The following is a description of a gene set: studied in species Homo sapiens Human Gene Set: GSE37301_MULTIPOTENT_PROGENITOR_VS_GRAN_MONO_PROGENITOR_DN Expression profiling of Rag2-deficient Ets1++ and Rag2-deficient Ets1-- mature NK cells and WT bone marrow progenitors, WT T cells, and WT Pro B cells Genes down-regulated in multipotent progenitors versus granulocyte-monocyte progenitors. from publication Ramirez K, Chandler KJ, Spaulding C, Zandi S, Sigvardsson M, Graves BJ, Kee BL (PMID 22608498), and this is the list of marker genes: SRP19, QSOX1, SERPING1, AP1AR (NCBI Gene Id 55435), GPC4, TOR1AIP2, FMOD, SAAL1, REEP1, PDIA5, SLC31A1, PSMA7, ART3, RELA, HDC, TRPM7, PI4K2A, DDR1, RNF19B, DAXX, FBXW4, MX2, CLIC4, GPD2, RIPK1, PROCR, OXCT1, ALOX12, LTBP2, TBK1 (TANK binding kinase 1), EXO1, KLF9, ANKRD1, FRYL, KLF6, LY75, IL6ST, TUBB6, CMTR1, TAPBP, LARS1, AGFG1, MARK1, IFIH1, NMI, CRYBG1, IFIT1B, CARS1, FAM3B, EIF2AK2, PNP (NCBI Gene Id 4860), LGALS3BP, GJA4, PSMB9, PSEN1, PACS1, CXCL10, GTF2H1, LYSMD2, TSR1, IFIT2, NCK1, ABCG1, G3BP2 (G3BP stress granule assembly factor 2), PML, PSMB10, MYD88, CASP4, SAMHD1, CCR9, RSAD2, PKDCC, CMPK2, MED28, IL13RA1, GPANK1, DBNL (drebrin like), DKK3, RAD52, SNX10, MMP13, PPA1, TAP1, B4GALNT2, PHC2, PYCR2, NUB1, INSIG1, TAB2, ARL2BP, WARS1, TRAFD1, ZNFX1, STAT1, CLDN8, PTPRC, ATP11A, ITPR1, BIRC3, NPDC1, CD3D, NOP2, PSMB8, CSK, NAMPT, EXTL3, INTS8, CARM1, USP18, ITGB3, PAGR1, IL7R, LMO7, BMPR1A, HIP1R (huntingtin interacting protein 1 related), TRDMT1, HSPA1A, XDH, S100A4, IRF8, MAP4K3, JUN, TMEM50B (transmembrane protein 50B), BATF3, IFRD1, LMO2, HLA-G, PPRC1, NFKB2, KITLG, TFDP1, UBA7, NR1H2, TSSK1B, CDH8, POLD3, GRAMD2B, PXK, HLA-DMA, C8orf33 (NCBI Gene Id 65265), SOCS2, APOBEC1, GBP7 (guanylate binding protein 7), OSMR, BDKRB2, RGCC, ADAM23, MTNR1A, LCN2, ISG15, DSC1, IRF1, HPCA, ISG20, GTF2F2, CRIPTO, CCL13, MARK2, GBP4, GLCE, UBL3, PLPPR2, TRIO, GTPBP2, IRF7, RAD1, ADAM9, ATAD1, PAWR, CEBPG, LYN, SLC10A3 (solute carrier family 10 member 3), PLA2G4A, OGFR, CDC23, FCGR1A, GADD45G, TMEM229B, ABHD16A, ICAM1, HES1, AP1G2, MARCHF5 (NCBI Gene Id 54708), CCNG2, ZNRF1, KRT18, GBP2, NT5C3B, CCL7 (NCBI Gene Id 6354), IRGM, MYO5B, UBR4, E2F8, IFIT3, POLR2A, KRT77, OMD, ORM1, CLIC3, SLTM